The following is a description of a gene set: species: Homo sapiens Human Gene Set: GSE1112_OT1_VS_HY_CD8AB_THYMOCYTE_RTOC_CULTURE_UP from publication Yamagata T, Mathis D, Benoist C (PMID 15133507) Genes up-regulated in CD8 alphabeta OT1 thymocyte RTOC culture versus CD8 alphabeta HY thymocyte RTOC culture. Four independent chip hybridization with RNAs from four independent RTOC cultures., and this is the list of marker genes: CEP97, PCSK7, NISCH, ZNF138, LRRC69, CDK4, CYSLTR1, GSTP1, NFE2 (NCBI Gene Id 4778), KCNK6, CCL5, UPK1B, NARS2, CBX6, CCL26, PI4K2A, UBAP2L, ACIN1, NME7, PALLD, MRPS7, SLC26A6, BORCS5, GPI, ZNF442 (NCBI Gene Id 79973), MRPL38, CLEC4G, FLVCR2, MGME1, C1QC, ENO1, APEX2, PHPT1, PIK3R6, SLC7A8, DCANP1, GFRA3, HTT, SYNGR2, ERC2, MPDU1, GTF3C4, SCD, SLC25A20, STOML2, SHISA3, GPX2, PIEZO1, UBTF, PDGFC, TBXAS1, TKT, NDUFV1, CDK19, PRMT5, MRGPRX1, APOO, GID8, ALOX15, NFXL1, MPV17 (NCBI Gene Id 4358), SLX4, NUBP1, BLVRB, PMVK, REEP5, BPIFA3, CRISP2, CD209, CAMK1D, NEMP2, LANCL2, XXYLT1, BLTP2, EMB, AKT1S1, EPOP, HSD11B1, SLC23A3, DLX6-AS1, ZC3H3, PACS1, HSPB1, ECH1, LENG8, PSME3, NPRL2, TBRG4, SLC47A1, KRT40, TRIB2, SLCO3A1, MAF, PALB2, ALDOA, RIDA, NUP93, GAS2L3, COL11A1, CCL22, INF2, SPINT2, SCAND2P, SDC4, MORC4, IRF4, SNHG29, GGTA1, TOMM22, ASTE1, KRT4, EDC4, AKR1B1 (aldo-keto reductase family 1 member B), WIZ, APOL4, CCL17, C17orf58, OLFM2, SRSF5, EEPD1, PPP1R9B, RAB8A, TMEM71, KISS1R, DSG1, KCNE1, TMT1A, MLST8, EHD2, AIFM1, ARHGAP25, ZFP36L1, INTS7, EQTN (NCBI Gene Id 54586), PLOD1, WBP2NL, PDGFB, RERE, CARD9, MFHAS1, MVD, MTMR14, FAM110B, HLA-B, CNOT3, DYRK2, MS4A3, ACOX3, RYBP, SPAG4, MRPL48, SNX8, EEF2K, CKS1B, TTC9C, CDC37, HPD, MAOA, SLA, FADS2, PITRM1, ZBTB46, CBX5, AP1B1, EIF4G1, SNX17, CD200R1, UBE2C, CISH, MMS19, CASC2, RABEPK, EDDM3B, INO80E, QSOX1, PRPF8, EPHX1, TRIM48, APBB1IP, SERPINB5, ARL4C, NUDT16L2P (NCBI Gene Id 152195), STAB1, IL18BP, LRRC74B, ALAS1 (NCBI Gene Id 211), PRPS1, SLC17A8, SFT2D2, H3C11, MTHFD1, FCER2, ALDH7A1, OXA1L, EXT1, CYYR1, HAO1, ADAMTSL4, TP53, HSP90AB1